Given this list of marker genes Tnfsf4, Foxp3, Il27ra, Ddit3, Parp1, Ubr5, Arg2, Tusc2, Nckap1l, Tlr2, Otud5, Il36rn, Tlr4, Ifng, Tgfb1, Prnp, Il12b, Il12a, Vsir, here is a description of the gene set: Mouse Gene Set: GOBP_NEGATIVE_REGULATION_OF_INTERLEUKIN_17_PRODUCTION Any process that stops, prevents, or reduces the frequency, rate, or extent of production of any member of the interleukin-17 family of cytokines. species: Mus musculus